The following is a description of a gene set: from publication Xie S, Zhou N, Su N, Xiao Z, Wei S, Yang Y, Liu J, Li W, Zhang B (PMID 38577019) Mouse Gene Set: XIE_TRASTUZUMAB_CARDIOTOXICITY_MMU_MIR_133A_3P_GENES studied in species Mus musculus Abstract: Trastuzumab-induced cardiotoxicity (TIC) is a common and serious disease with abnormal cardiac function. Accumulating evidence has indicated certain non-coding RNAs (ncRNAs), functioning as competing endogenous RNAs (ceRNAs), impacting the progression of cardiovascular diseases. Nonetheless, the specific involvement of ncRNA-mediated ceRNA regulatory mechanisms in TIC remains elusive. The present research aims to comprehensively investigate changes in the expressions of all ncRNA using whole-transcriptome RNA sequencing. The sequencing analysis unveiled significant dysregulation, identifying a total of 43 circular RNAs (circRNAs), 270 long noncoding RNAs (lncRNAs), 12 microRNAs (miRNAs), and 4131 mRNAs in trastuzumab-treated mouse hearts. Subsequently, circRNA-based ceRNA networks consisting of 82 nodes and 91 edges, as well as lncRNA-based ceRNA networks comprising 111 nodes and 112 edges, were constructed. Using the CytoNCA plugin, pivotal genes - miR-31-5p and miR-644-5p - were identified within these networks, exhibiting potential relevance in TIC treatment. Additionally, KEGG and GO analyses were conducted to explore the functional pathways associated with the genes within the ceRNA networks. The outcomes of the predicted ceRNAs and bioinformatics analyses elucidated the plausible involvement of ncRNAs in TIC pathogenesis. This insight contributes to a better understanding of underlying mechanisms and aids in identifying promising targets for effective prevention and treatment strategies., and this is the list of marker genes: Gabpb2, Gatad2b, Hcn1, Sox5, Sh3bp2, Cfap61, Rgs3, Cttn, Atxn7l1, Wnt5b, Crispld2, Fryl, Mecom, Tmod2, Slc1a4, Celf1, Fbxl19 (NCBI Gene Id 233902)